Given this list of marker genes Ccna2, Crk, Slc25a33, Igf1, Igf1r, Fbn1, Itgb3, Ctnnb1, Ghsr, Tgfb1, Cfl1, Syap1, Pten, here is a description of the gene set: studied in species Mus musculus Any process that results in a change in state or activity of a cell (in terms of movement, secretion, enzyme production, gene expression, etc.) as a result of an insulin-like growth factor stimulus. Mouse Gene Set: GOBP_CELLULAR_RESPONSE_TO_INSULIN_LIKE_GROWTH_FACTOR_STIMULUS